The following is a description of a gene set: studied in species Mus musculus Any complex formed of proteins that act in mismatch repair. Mouse Gene Set: GOCC_MISMATCH_REPAIR_COMPLEX, and this is the list of marker genes: Pms1, Msh2, Msh6, Mlh3, Mlh1 (mutL homolog 1), Msh3, Pms2